The following is a description of a gene set: part of: Signaling by FGFR species: Homo sapiens Reactome Pathway: Signaling by FGFR1 The 22 members of the fibroblast growth factor (FGF) family of growth factors mediate their cellular responses by binding to and activating the different isoforms encoded by the four receptor tyrosine kinases (RTKs) designated FGFR1, FGFR2, FGFR3 and FGFR4. These receptors are key regulators of several developmental processes in which cell fate and differentiation to various tissue lineages are determined. Unlike other growth factors, FGFs act in concert with heparin or heparan sulfate proteoglycan (HSPG) to activate FGFRs and to induce the pleiotropic responses that lead to the variety of cellular responses induced by this large family of growth factors. An alternative, FGF-independent, source of FGFR activation originates from the interaction with cell adhesion molecules, typically in the context of interactions on neural cell membranes and is crucial for neuronal survival and development.<br><br>Upon ligand binding, receptor dimers are formed and their intrinsic tyrosine kinase is activated causing phosphorylation of multiple tyrosine residues on the receptors. These then serve as docking sites for the recruitment of SH2 (src homology-2) or PTB (phosphotyrosine binding) domains of adaptors, docking proteins or signaling enzymes. Signaling complexes are assembled and recruited to the active receptors resulting in a cascade of phosphorylation events.<br><br>This leads to stimulation of intracellular signaling pathways that control cell proliferation, cell differentiation, cell migration, cell survival and cell shape, depending on the cell type or stage of maturation.<br>, and this is the list of marker genes: FGF8, HRAS, GIPC1, SOS1, ANOS1, FGF3, CBL, FGF17, PTPN11, PIK3R1, UBA52, FGF5, RPS27A, UBC, FRS3, FGF10, MAPK3, PLCG1, PIK3CA, FLRT1, BRAF, FRS2, FGF9, SHC1, GAB1, FGF18, FGF2, SPRY2, FGFR1, FLRT3, FGF4, SPRED2, SRC (SRC proto-oncogene, non-receptor tyrosine kinase), FGF1, MAPK1, FGF22, PPP2CB, SPRED1, NRAS, FGF20, GRB2, TGFBR3, FGF23, FGFRL1, FLRT2, UBB, KRAS, KL, MKNK1, PPP2CA, PPP2R1A, FGF6